The following is a description of a gene set: Obesity is strongly correlated with type 2 diabetes mellitus, a common disorder of glucose and lipid metabolism. Although adipocytes are critical in obesity, their role in diabetes has only recently been appreciated. We conducted studies by using DNA microarrays to identify differences in gene expression in adipose tissue from lean, obese, and obese-diabetic mice. The expression level of over 11,000 transcripts was analyzed, and 214 transcripts showed significant differences between lean and obese mice. Surprisingly, the expression of genes normally associated with adipocyte differentiation were down-regulated in obesity. Not all obese individuals will become diabetic; many remain normoglycemic despite profound obesity. Understanding the transition to obesity with concomitant diabetes will provide important clues to the pathogenesis of type 2 diabetes. Therefore, we examined the levels of gene expression in adipose tissue from five groups of obese mice with varying degrees of hyperglycemia, and we identified genes whose expression strongly correlated with diabetes severity. This group included many genes that are known to be involved in signal transduction and energy metabolism as well as genes not previously examined in the context of diabetes. Our data show that a decrease in expression of genes normally involved in adipogenesis is associated with obesity, and we further identify genes important for subsequent development of type 2 diabetes mellitus. species: Mus musculus from publication Nadler ST, Stoehr JP, Schueler KL, Tanimoto G, Yandell BS, Attie AD (PMID 11027337) Genes up-regulated in adipose tissue from obese mouse strains compared to the lean ones. Mouse Gene Set: NADLER_OBESITY_UP, and this is the list of marker genes: Csf1r, Basp1, Pld3, Lrp1, Cfl1, Ctsl, Dusp1 (NCBI Gene Id 98098), Ctsa, Mrc1, Hcls1, Fcer1g, Alox5ap, Pfn1, Sec13, Dad1, Cryab, Col1a1, Cd68, Ctsk, Tln1, Pitpna, Mt2, Flna (NCBI Gene Id 245705), Lep, C1qb, Laptm5, Ctsz, Ckb, Ccl9, Capg, Ifi30, Fbln2, Ctsd, Ucp2, Pltp, Serpinf1, Tpm4, Lgmn (legumain), Psap, Mif, Pea15a, Mfge8, Ctss, Grn, Dynlt1b, Atp6v1c1, Bgn, Ifi27, Lbp, Cd53, Plin2, Tpd52, Selplg, Postn, Lgals3, Ctsb, Fxyd5, Nedd8, Fcgr3, Cstb